Given this list of marker genes NUP205, NUP160 (nucleoporin 160), NUP54, NUP98, PSIP1, TPR, BANF1, vpu, SEC13, NUP58, NUP210, NUP88, POM121C, NUP62, NUP133, SEH1L, POM121, HMGA1, NUP214, RAE1, vpr, AAAS, NUP93, NUP43, NUP107, NUP85, NUP50, NUP188, NUP155, gag, gag-pol, NDC1, NUP37, NUP153, NUP42, RANBP2, rev, NUP35, vif, KPNA1, here is a description of the gene set: studied in species Homo sapiens Reactome Pathway: Vpr-mediated nuclear import of PICs Vpr appears to function in anchoring the PIC to the nuclear envelope. This anchoring likely involves interactions between Vpr and host nucleoporins. part of: Interactions of Vpr with host cellular proteins